The following is a description of a gene set: Mouse Gene Set: WP_ROBO4_AND_VEGF_SIGNALING_PATHWAYS_CROSSTALK Robo4 and VEGF signaling pathways crosstalk species: Mus musculus, and this is the list of marker genes: Rac1, Slit2, Robo4, Kdr, Vegfa, Src